The following is a description of a gene set: from publication Petretto E, Sarwar R, Grieve I, Lu H, Kumaran MK, Muckett PJ, Mangion J, Schroen B, Benson M, Punjabi PP, Prasad SK, Pennell DJ, Kiesewetter C, Tasheva ES, Corpuz LM, Webb MD, Conrad GW, Kurtz TW, Kren V, Fischer J, Hubner N, Pinto YM, Pravenec M, Aitman TJ, Cook SA (PMID 18443592) Up-regulated cis-regulated expression quantitative loci (cis-eQTL) in the heart that colocalize with previously mapped cardiac mass QTLs. Left ventricular mass (LVM) and cardiac gene expression are complex traits regulated by factors both intrinsic and extrinsic to the heart. To dissect the major determinants of LVM, we combined expression quantitative trait locus1 and quantitative trait transcript (QTT) analyses of the cardiac transcriptome in the rat. Using these methods and in vitro functional assays, we identified osteoglycin (Ogn) as a major candidate regulator of rat LVM, with increased Ogn protein expression associated with elevated LVM. We also applied genome-wide QTT analysis to the human heart and observed that, out of 22,000 transcripts, OGN transcript abundance had the highest correlation with LVM. We further confirmed a role for Ogn in the in vivo regulation of LVM in Ogn knockout mice. Taken together, these data implicate Ogn as a key regulator of LVM in rats, mice and humans, and suggest that Ogn modifies the hypertrophic response to extrinsic factors such as hypertension and aortic stenosis. species: Rattus norvegicus Human Gene Set: PETRETTO_HEART_MASS_QTL_CIS_UP, and this is the list of marker genes: NOX4, DGAT2, TST, UQCC6, RNF6, CARD9, PLEKHB1, RPUSD4, PXYLP1, MAN1A1, VPS52, SPARC, OGN (osteoglycin), TOR1B, RAMAC, HMCN2, SDHB, NET1, CSNK2A1, C5orf15, ADRA1B, TRAK2, TLE6, FNIP1, GPLD1, PLEC, DHDDS, AUTS2, PILRA, VAMP1 (NCBI Gene Id 6843), ABHD16A (abhydrolase domain containing 16A, phospholipase), BHLHE40, FCER2, TRIO